The following is a description of a gene set: The chemical reactions and pathways resulting in the formation of glyceraldehyde-3-phosphate, an important intermediate in glycolysis. species: Mus musculus Mouse Gene Set: GOBP_GLYCERALDEHYDE_3_PHOSPHATE_BIOSYNTHETIC_PROCESS, and this is the list of marker genes: Eno1, Pck1, Tkt, Pcx (NCBI Gene Id 18563), Slc25a10, Gpd1, Tpi1, Pgk1, Pgam1, Gapdh, Mdh1, Mdh2 (malate dehydrogenase 2, NAD (mitochondrial))